The following is a description of a gene set: Mouse Gene Set: GOBP_REGULATION_OF_BRANCHING_INVOLVED_IN_URETERIC_BUD_MORPHOGENESIS Any process that modulates the rate, frequency or extent of branching involved in ureteric bud morphogenesis, the process in which the branching structure of the ureteric bud is generated and organized. The ureteric bud is an epithelial tube that grows out from the metanephric duct. The bud elongates and branches to give rise to the ureter and kidney collecting tubules. species: Mus musculus, and this is the list of marker genes: Agtr1b (NCBI Gene Id 11608), Pax2, Nog, Lhx1, Six1, Six2, Agtr2, Lgr4, Tgfb1, Six4, Tacstd2, Maged1, Hoxb7, Wnt2b, Grem1, Sall1, Sox8 (NCBI Gene Id 20681), Vegfa, Gdnf, Agt, Pax8, Sox9, Smo, Agtr1a (NCBI Gene Id 72294), Bmp4